The following is a description of a gene set: Reactome Pathway: Nephrin family interactions Nephrin (NPHS1) is a member of the Super-IgG-Molecule family and is most prominently expressed in kidney podocytes. It is a major if not the most important structural component of the slit diaphragm, a modified adherens junction in between these cells. NPHS1 has an extracellular domain that contains eight distal IgG like domains and one proximal fibronectin type III domain, a transmembrane domain and a short intracellular domain. NPHS1 molecules show both homophilic and heterophilic interactions. Among heterophilic interaction partners, slit diaphragm proteins such as Kin of IRRE-like protein 1 (KIRREL, Nephrin-like protein 1, NEPH1), KIRREL3 (NEPH2) and KIRREL2 (NEPH3) were shown to stabilize the slit diaphragm structure. Intracellularly Podocin (NPHS2), CD2 associated protein (CD2AP) and adherins junction associated proteins like IQGAP, MAGI, CASK and spectrins all interact with NPHS1. Hence it seems to play a major role in organizing the molecular structure of the slit diaphragm itself and via its binding partners links it to the actin cytoskeleton. NPHS1 tyrosine phosphorylation by the Src kinase FYN initiates the PI3K-AKT signaling cascade, which seems to promote antiapoptotic signals. species: Homo sapiens part of: Cell-Cell communication, and this is the list of marker genes: CASK, KIRREL1, IQGAP1, ACTN3, NCK2, PIK3CA, FYN, WASL, PIK3R1, ACTN2, PIK3CB, KIRREL3, ACTN1, NPHS2, ACTN4, KIRREL2, NCK1, MAGI2, PIK3R2, SPTAN1, SPTBN1, NPHS1, CD2AP